The following is a description of a gene set: species: Homo sapiens Human Gene Set: HP_ECTROPION_OF_LOWER_EYELIDS Ectropion of lower eyelids, and this is the list of marker genes: MEGF8, DHODH, CDH1, RNU4-2, ADNP, RNF2, EFEMP1, DLX4, CTNND1